Given this list of marker genes PGF, EHD3, MN1, BLTP3B, COL1A2, MRPL32, ADAMTSL5, CAMSAP2, H1-2, SEMA5B, HES7, TNFRSF25 (NCBI Gene Id 8718), BBC3, TESPA1, HOPX, GCGR (NCBI Gene Id 2642), MOG (myelin oligodendrocyte glycoprotein), GABARAPL2 (NCBI Gene Id 90769), RPL22, FCGR2B, TCF7, TAFA3, RXFP3, KLF2, NMNAT3, TMEM132A, IL18R1, ADARB1, PLK5, TESC, AGTR1, PDCD2L, FBN2, CBX7, USP3, ACP6, PRIMA1, UQCC4, MORC1, DZIP1, IGLON5, VKORC1, FAM246A, GPR183, PTPRN2, FGF5, VAMP4, UCN2, NXF3, CHST10, CDH4, WT1, TMUB1, SIDT1, SSPOP, MRPL33, ZHX2, LMBR1, VIPR1, NFATC2, MAP3K7CL, DMRTA1, EMB, POLR1D, ACAN, COX10, EVL, LRWD1, SLC22A16, PDCD2, TLE1, EID2 (NCBI Gene Id 163126, EP300 interacting inhibitor of differentiation 2), CLDN2, ITGAX, CLIP1, COMMD9, SPAG16, MIR448, MYOZ3, LY6H, PIK3IP1, HLA-B, PHACTR1, ZNRF2, TMEM52B, CCT4, TMEM33, GPR63, FAM135B, TMEM169, PKP1, GLOD5, TAS1R3, ATG9B, TSKS, LPAR6, GZMM, NPTN, APLN, SLC6A15, SYS1, OLFM5P, BOLA2, ABCG8, HS3ST6, PPM1L, LEF1, C1QTNF7, NDUFA3, FOLR2, RPS19, GPR180, MAN2A2, SLC4A1AP, IL1RL1, SMNDC1, GALNT10, CACNB3, JMJD6, MED21, CHRNA5, CC2D2B, EPSTI1, EFNB3, CMYA5, LZTS2, KLRK1, ELP3, SNU13 (small nuclear ribonucleoprotein 13), KLK8, WWP1, TANC1, NLE1, PARP8, FCGRT, BTBD6, CDK3, TMEM25, RPL30, ATOH8, MED6, RNF138, GDF5, TRMO, AFP, PIP4P2, IL7R, ACTL7B, CYYR1, KBTBD11, KANK1, KRTCAP2, SH2B1, DDX18, PISD, MIR24-2, ZNRF1, CASKIN1, TBC1D21, MIR99B, RPL13, RPS23, KLRD1, BLOC1S4, PITX3, DNAJC15, PWWP3B, CHCHD2, here is a description of the gene set: studied in species Homo sapiens The development, homeostasis and function of B lymphocytes involve multiple rounds of B cell receptor (BCR)-controlled proliferation and prolonged maintenance. We analyzed the role of transcription factor Zfx, a recently identified regulator of stem cell maintenance, in B cell development and homeostasis. Conditional Zfx deletion in the bone marrow blocked B cell development at the pre-BCR selection checkpoint. Zfx deficiency in peripheral B cells caused impaired generation of the B-1 cell lineage, accelerated B cell turnover, depletion of mature recirculating cells, and delayed T-dependent antibody responses. Zfx-deficient B cells showed normal proximal BCR signaling, but impaired BCR-induced proliferation and survival. This was accompanied by aberrantly enhanced and prolonged integrated stress response, and delayed induction of Cyclin D2 and Bcl-xL proteins. Thus, Zfx restrains the stress response and couples antigen receptor signaling to B cell expansion and maintenance during development and peripheral homeostasis. Genes down-regulated in B lymphocytes: control versus stimulated by anti-IgM. from publication Arenzana TL, Smith-Raska MR, Reizis B (PMID 19329779) Human Gene Set: GSE13547_CTRL_VS_ANTI_IGM_STIM_BCELL_2H_DN